The following is a description of a gene set: Mouse Gene Set: GOBP_CGMP_CATABOLIC_PROCESS species: Mus musculus The chemical reactions and pathways resulting in the breakdown of cyclic GMP, guanosine 3',5'-phosphate., and this is the list of marker genes: Pde2a, Pde10a, Pde9a, Pde5a, Pde1a